The following is a description of a gene set: species: Homo sapiens The process in which a rRNA, ribosomal ribonucleic acid, is transported from the cytosol into the mitochondrial matrix. Human Gene Set: GOBP_RNA_IMPORT_INTO_MITOCHONDRION, and this is the list of marker genes: TST, TOMM20L, TOMM20, PNPT1, MRPL18